The following is a description of a gene set: Human Gene Set: HP_EEG_WITH_GENERALIZED_SLOW_ACTIVITY EEG with generalized slow activity Diffuse slowing of cerebral electrical activity recorded along the scalp by electroencephalography (EEG). studied in species Homo sapiens, and this is the list of marker genes: CDKL5, CYP27A1, AP2M1, NEXMIF, DPAGT1, KPTN, TREM2, GRIA4, PSEN1, RNF13, CHMP2B, MECP2, SYNGAP1, GRN, DOLK, CHD2, TMEM106B, VCP, SQSTM1, SLC2A1, HID1, ALDH7A1, SLC6A1, MAPT, PLPBP, LMNB1, SCN1A, MTHFS, CNTNAP2